Given this list of marker genes TMTC1, PAM, PBK, MARCHF5, XPO1, ITGA5, JADE1, CLOCK, CDK17, ZBTB10, DYNC1LI2, LAMTOR3, SCRN3, MOSPD2, AQP4, INO80D, IER3, INPP5A, SRGAP2C, EBF3, LARP4, UQCC6, ZNF230, POLR3A, MEDAG, VPS52, SAMD4B, TAB2, FYB1, C2CD2, KMT2A, EPPIN-WFDC6, PRIMPOL, CTLA4, HAVCR1, SPPL3, RABGAP1L, CDC7, RNF145, KDM4A, TFG (trafficking from ER to golgi regulator), FOSL1, SLITRK4, BAZ1A, ANLN, FGL2, CTNND1, TSGA10, UTRN, ACSL4, ARTN, ATP6V1C1, KCTD3 (potassium channel tetramerization domain containing 3), CNN3, ARID4A, MGAT4A, FCHO2, AMMECR1L, SETBP1, HECTD2, NGRN, ARHGAP35, PPCS, TAF5L, DYNC1H1, GAS2L3, CD24, TASOR2 (NCBI Gene Id 54906), SH2B3, KIF5B, NLGN3, MARF1, ANKRD28, ATP2B2, AFF4, CEP170, FOXM1, NUP88, BAHCC1, TAOK1 (TAO kinase 1), RAB11FIP2, APPL2, MAP4K3, HMBOX1, RABEP1 (NCBI Gene Id 9135), ZNF217, RGL2, TTC14, SGCZ, SNX24, ASH1L, BOD1L1, CFL2, CDC14A, PHF6, LCOR, HDLBP, MOSMO, CCNJ, GCNT2, FAM149A, ATRN, ATF7, BBIP1, ARK2N, HSBP1, NKAIN3, BEST1, CCDC6, CRK, ELAVL3, QKI, CCNI2 (cyclin I family member 2), C6orf62, UGT8, C11orf96, USP8, SCAMP1, ROCK1, PTP4A1, YTHDF3, FRS2, CDKN1B, CAPRIN1, PDE12, SUCO, RICTOR, GSAP, CPEB2, NABP1, LRRFIP2, NCKAP1, ZIC5, SNX2, VGLL4, NBPF3, SPAG9, TRIP11, C1orf53, TNRC6C, RHOQ, ELK3, VCL, APLN, KIF5C, CPEB4, SAMD8, RIPPLY3, STT3A (STT3 oligosaccharyltransferase complex catalytic subunit A), CCDC198, GLT1D1, CCDC47, DDIAS, ARHGEF2, RNF111, ELF2 (E74 like ETS transcription factor 2), WWTR1, ZBTB41, RUFY2, APC, FNDC3B, EPB41L2, BRD1, MFSD2A, SMAD5, TSEN34, RAB9B, SCAI, FAM171B, YWHAB, ZBTB20, ACSL1, here is a description of the gene set: Human Gene Set: MIR4255 from publication Chen Y, Wang X (PMID 31504780) studied in species Homo sapiens Genes predicted to be targets of miRBase v22 microRNA hsa-miR-4255 in miRDB v6.0 with MirTarget v4 prediction scores > 80 (high confidence targets).